Given this list of marker genes Casp4 (caspase 4, apoptosis-related cysteine peptidase), Il18, Ifng, Il18rap, Akt1, Nlrp6, Il18r1, Cyld, Pdgfb, Pik3r1, Ticam2, here is a description of the gene set: Mouse Gene Set: GOBP_CELLULAR_RESPONSE_TO_INTERLEUKIN_18 Any process that results in a change in state or activity of a cell (in terms of movement, secretion, enzyme production, gene expression, etc.) as a result of an interleukin-18 stimulus. studied in species Mus musculus